The following is a description of a gene set: species: Homo sapiens Human Gene Set: HP_DYSGENESIS_OF_THE_BASAL_GANGLIA Structural abnormality of the basal ganglia related to defective development. Dysgenesis of the basal ganglia, and this is the list of marker genes: CAMSAP1, TUBB (tubulin beta class I), TUBA1A, TUBB2B, TUBB3